The following is a description of a gene set: studied in species Mus musculus Mouse Gene Set: MIR_7052_3P from publication Chen Y, Wang X (PMID 31504780) Genes predicted to be targets of miRBase v22 microRNA mmu_miR_7052_3p in miRDB v6.0 with MirTarget v4 prediction scores > 80 (high confidence targets)., and this is the list of marker genes: Srpra, S100a10, Bcl6, Zfp983 (NCBI Gene Id 73229), Spag17, Grap2, Gprc5b, Nr4a2, Fpgs, Slc29a4, Pate9, Flna, Ppp2r5e, Ptpn14, Ufm1, Calca, Adipor1, Mrpl13, Frmd5, Epn3, Wdr26, Dnmt3a, Smarca4, Gcfc2, Tspan33, Zfp523 (zinc finger protein 523), Hs6st1, Dennd2d, Gns, Slc35b3, Mrpl10, Tsc1, C1s2, Tbccd1, Zfp780b, Nipal3, Trio, Slc31a2, Speer4d, Tmem64, Gdnf, Klhl25, Zfp398, Abcc6, Lhfpl4, Setd3, Zmym3, Cdca7l, Mfsd2b, Ccser2, Cask, Gspt2, Rbm48, Dhrs9, Drp2, Ranbp10, Flnb, Mapre1, Timm22, Fdx1, Strip2, Zfp423, Rasgef1b, Qng1, Ptpn5, Tjp2, Sema5b, Mindy2 (MINDY lysine 48 deubiquitinase 2), Fyco1, Pdap1, Ube2l3, Prkcb, Glrx3, Speer4c1, Wapl, Hk2, Nhsl2, BC035044 (NCBI Gene Id 232406), Mettl21e, Sema3a, Smg5, Bace1, Orai2